Given this list of marker genes NUDT7, PDE6D, DTD1, JPT2, SKP2, USO1, MICA, CLPB (ClpB family mitochondrial disaggregase), STC2, KYAT3, LPXN, STAP2, PSMG1, CSNK2B, FNBP1, PCMT1, APEH, SPATC1L, CENPM (NCBI Gene Id 79019, centromere protein M), BLM, ENSG00000291211, TMUB1, LSM2, SEC11A, MRI1, C8orf88, GLE1, DRAM2, EIPR1, GLB1, AP3M1, NUP37, KHDRBS1 (NCBI Gene Id 10657), GLT8D1, RBBP7, FANCL, AGO3, SPAG16, KEAP1, E2F7, MRPS16, HNRNPLL, PFKL, SIRT5, PSD4, CRAT, ORC3, CTCF, TBCD, CERS2, FBXO22, GFM2, ORC6, PSMB8, LGMN, EED, MCM5, KIF2A, CLPX, PARK7, MOB3A, STARD3NL, TIMM29, INVS, CHAF1B, LMNB2, CRTAP, PAK1, CETN3, COMMD8, MAD2L2, MLH1 (mutL homolog 1), SNRPA, GMPR2, CAPG, DROSHA, KTN1, RPL23AP7, SHCBP1, TXN2, CCDC25, VDAC3, TFPT, UQCRC1, TIPIN, ANKZF1, TMEM237, LCP1, CZIB, ATP5F1B, PTPN7, ASF1B, LAYN, GPANK1, OSBPL3, SPINT2, CD79B, GNPAT, SNRNP25, WDR76, CPSF3, TGFB1I1, SASH3, MRPL52, MAD2L1, COA6, PRDX4, C4orf46, TRAFD1, MTMR4, ZNF248, PPIH, EFEMP2, PAICS, SDHAF4, FANCA, CHCHD2, PPA2, APAF1, RAN, TMEM107, FARSA, PKN3, REPIN1, DPY19L2P2, TFB1M, HMGB2, EXO1, HIRIP3, ZDHHC12, ZNF672, MPHOSPH9, GRB2, NEMP1, ETFA, CLNS1A, SORD, IAH1, SLC25A11, UBE2I, GPR157, NCAPD3, CGAS, VPS26C, TBL1XR1, LRP11, DLEU1, PXMP4, LSS, APOL2, DENND10, HDAC3, STYXL1, SPATS2L, ETFDH, CCDC34, VBP1, ACP5, TMEM97, VAMP8, CMSS1, DRG1, UBE2Q2P13, VKORC1, CDC6, CCT8, EBI3, UNC45A, YWHAQ (tyrosine 3-monooxygenase/tryptophan 5-monooxygenase activation protein theta), PIAS3, PLEKHJ1, GET1, HADHB, EDC3, WDR33, SLC25A20, IFI16, FAM120A, ARPC1B, NEK2-DT, RIC8B, PKM, C1orf216, ITPR3, UGP2, VDAC1, NUP188, METAP1, HNRNPUL2, EGLN3, MYCBP, CCNA2, CD53 (NCBI Gene Id 963), MAP2K1, P4HA1, ANXA11, DUT, AP3B1, MTFR1, RBX1, here is a description of the gene set: studied in species Homo sapiens Human Gene Set: GSE17974_1H_VS_72H_UNTREATED_IN_VITRO_CD4_TCELL_DN The aim of this dataset was to study in detail the transcription kinetics initiated by cytokine IL-4 in early differentiation of Th2 cells. from publication Elo LL, Järvenpää H, Tuomela S, Raghav S, Ahlfors H, Laurila K, Gupta B, Lund RJ, Tahvanainen J, Hawkins RD, Oresic M, Lähdesmäki H, Rasool O, Rao KV, Aittokallio T, Lahesmaa R (PMID 20620947) Genes down-regulated in comparison of untreated CD4 T cells at 1 h versus the untreated cells at 72 h.